The following is a description of a gene set: studied in species Mus musculus from publication Tabula Muris Consortium (PMID 32669714) Mouse Gene Set: TABULA_MURIS_SENIS_LUNG_NEUTROPHIL_AGEING, and this is the list of marker genes: Lcn2, Retnlg, Scgb1a1, Sftpc, Klf2, Gyg1, Wfdc17, Smpdl3a, Vim, Wfdc21, S100a8, Lrg1, Gapdh, Prr13, Ifitm2, Ifitm1, Tspo